The following is a description of a gene set: Human Gene Set: ZHONG_PFC_MAJOR_TYPES_INTERNEURON species: Homo sapiens from publication Zhong S, Zhang S, Fan X, Wu Q, Yan L, Dong J, Zhang H, Li L, Sun L, Pan N, Xu X, Tang F, Zhang J, Qiao J, Wang X (PMID 29539641), and this is the list of marker genes: ARX (NCBI Gene Id 619216), DLX2, CELF4 (CUGBP Elav-like family member 4), PDE4DIP, ERBB4, DLX1, INA, LHX6, GAD2, NRXN3, GAD1, MEF2C, CXCR4, DLX5, MAF, SOX2-OT, PLS3, MEG3